Given this list of marker genes Micall2, Dennd4b, Rab3gap1, Madd (MAP-kinase activating death domain), Rab33b, Cd2ap, Rab9, Rab39, Rab35, Rab30, Rab4b, Rab33a (RAB33A, member RAS oncogene family), Dennd1a, Rab21, Rab12, Rab15, Dennd4c, Rab39b, Dennd3, Dennd4a, Gdi1, Rab9b, Rab4a, Sgsm3, here is a description of the gene set: species: Mus musculus An intracellular signaling cassette in which a small monomeric GTPase of the Rab subfamily relays a signal. Mouse Gene Set: GOBP_RAB_PROTEIN_SIGNAL_TRANSDUCTION